Given this list of marker genes EGF, P2RY1, AVPR1B, SIRT1, SIRT7, USP7, LHCGR, INS, ADIPOQ, CD244, EPM2AIP1, FOXO1 (forkhead box O1), PPP1R3E, C1QTNF3, SIK1 (NCBI Gene Id 54018), MST1, MIR107, SLC35B4, NTSR1, NLN, TCF7L2, PPP1R3A, PRKAG3, P2RY6, PTPN2, SIRT6, PPP4R3A, SERPINA12, GCG, ERFE, EP300, AP2A1, AKT1, GPER1, AKT2, MIR15B, ENPP1, MTCL2, IRS1, MIR195, GRB10, CRY1 (cryptochrome circadian regulator 1), DGKQ, PLEK, GSK3A, OGT, SMPD3, DDB1, CLTC, SELENOS, PRKAG1, RANBP2, GNMT, CLK2, TGFB1, PRKACA, HAS2, GCK, FBP1, C1QTNF12, ARPP19, IGF1, PTH, KAT2B, PPP4R3B, LEPR, PGP (NCBI Gene Id 79118), PPP1R3C, PPARGC1A, INSR, ADCYAP1R1, PPARA, PPP1R3D, SDHAF3, IGF2, PRKAG2, ZNF692, DYRK2, NFKB1, IRS2, SORBS1, MIR1271, PRKG1, PPP1R3B, PPP1CA, NR3C1, PPP1R3G, PTH1R, NNMT, KAT2A, INPP5K, PASK, PDGFB, WDR5, ACADM, PPP1R3F, SESN2, MIR103A1, NR0B1, GSK3B, SNCA, LEP, PDK2, DGAT2, here is a description of the gene set: Any process that modulates the frequency, rate or extent of the chemical reactions and pathways resulting in the formation of carbohydrates. Human Gene Set: GOBP_REGULATION_OF_CARBOHYDRATE_BIOSYNTHETIC_PROCESS species: Homo sapiens